The following is a description of a gene set: from publication Hill JA, Feuerer M, Tash K, Haxhinasto S, Perez J, Melamed R, Mathis D, Benoist C (PMID 18024188) Genes down-regulated in comparsion of sfActCD4 versus WTActCD4 (see Fig. 1 in the paper for details). The transcription factor Foxp3 is usually considered the master regulator for the CD4+CD25+ studied in species Homo sapiens Human Gene Set: GSE7460_FOXP3_MUT_VS_HET_ACT_TCONV_DN, and this is the list of marker genes: PTGFRN (prostaglandin F2 receptor inhibitor), ST6GALNAC3, DES, CALY, SPEM1, GNAZ, NRN1, TGM6, WEE1, SLC4A3, UBE2QL1, CRCT1, SP5, SH2D4B, LFNG, OIP5, ACOXL, UBTD2, CREB1, USP28, CTHRC1, ZNF605, ZDHHC23, EGR4, TICRR, PRPS2, SYNCRIP, PRKCA, BRD3, CORO6, REV1, TRIM23, IGSF21, ZNF106, ZNF462, NCOA5, MRO, KLHL12, NFIX, FAM169A (family with sequence similarity 169 member A), SMPD3, LTF, ABCB7, AKAP4, SHANK3 (SH3 and multiple ankyrin repeat domains 3), POLD3 (NCBI Gene Id 10714), CCL17, ANP32A, SMIM13, CEP89, GABRG3, CABYR, FABP1, NPR1, ANKRD34B, COL12A1, MDGA1, MAP4K1, AGBL5, SOCS2, EED, SHB, PC, BRINP3, SLC26A10P, HECTD2, ATXN10, IL6R (NCBI Gene Id 3570), ZRANB2, NCKIPSD, C9orf72, CUL5, CHST1, FBXW5, PPP3R1, POLR3G, ISOC1, KRT14, APOL2, PGBD1 (NCBI Gene Id 84547), PMCH, RPP25, TSPO2, TBC1D8, UMODL1, CABS1, WDR90, SETDB1, CHEK2, VSX2, CNKSR3, UBL7, TSC22D1, RIN2, PDGFD, TCF7, FGF13, STK38L, SLF2, STXBP4, BTBD1, DBF4, LRRC66, PAK4, PHF10, LONRF1, SMCO2, ICE1, LHX8, BAG4, CSN2, KANK1, CCDC57, PDE9A, C9 (NCBI Gene Id 12279), MAPKBP1, ART1, YPEL4, FOXD4L1, SAV1, APOE, NANP, AIRIM, PTOV1, PTPN11, DDX11, TTC9, ATP1B1, SRSF6, DNAJA2, SRRM1, CRYBA1, OLAH, HS6ST2, DNAJB12, ATPAF1, PRDM15, PUS10, IPO5, PITRM1, RPS6KB1, UPP2 (NCBI Gene Id 151531), COPS6, GREB1, FEM1B, ARHGAP42, AFF3, LRRC58, GPR101, DLG3, EPHX1, CNPY1, STAP1, TPD52L2, LELP1, NPAS4, GATAD2B, MEOX1, USP7, CDCA4, UBD, LIN7C, CAPRIN2, CMTM2, P2RX1, ZMIZ2, RNF133, LRRC72, EML4, PRDM16-DT, MFHAS1, SATB2, TNFRSF25, RS1, TNFSF4, RDH10, PARS2, DNAJC5G, PANK1, DAG1, OSBPL11, TRIM44, PSD, LRRC42, ERCC6L, COL11A2, HNRNPD, SNRPN, ADGRA1, NRP1, LIPK, ABTB3, APLNR, ZNF521, GPHN, RASD2, PRSS23 (serine protease 23), SPTLC3, RASGRF1